Given this list of marker genes Tnfsf4, Cd74, Sh3kbp1, Ctla4, Supt6, Nckap1l, Tgfb1, Cd19, Cd22, Bmi1, Tnfsf13b, Lyn, Pcid2, Pkn1, Cd320, Pten, Inpp5d, Exosc3, Mir181b-2, Tbx21, Aplf, Flt3, Shld1, Lilrb4a, Il2rg, Xbp1, Peli1, Il4, Stat5a, Ndfip1, Mef2c, Bcl2, Ankle1, Tlr9, Ptprc, Themis2, Tbc1d10c, Ifng (interferon gamma), Bank1, Il27ra, Zfp36l1, Bst1, Mlh1, Foxj1, Cyld, Parp3, Tlr4, Shld3, Stat5b, Tnfrsf13b, Il5, Nfatc2, Ptpn6, Kmt5c, Rc3h1, Btk, Il13 (interleukin 13), Mif, Mir150, Ighm, Cd40lg, Nfam1, Wnt3a, Trp53bp1, Tsc2, Ppp2r3c, Clcf1, Btla, Hmces, Ahr, Id2, Ighd, Sash3, Slamf8, Il21, Tnip2, Slc39a10, Tnfsf13, Sfrp1, Pagr1a, Cd28, Exosc6, Bad, Shld2, Il3, Il2, Mmp14, Tnfaip3, Laptm5, Fas, Msh2, Zfp36l2, Samsn1 (SAM domain, SH3 domain and nuclear localization signals, 1), BC037156, Pnp, Irs2, Ticam1, Slc15a4, Cd24a, Vav3, Chrnb2, Kmt5b, Siglecg, Cd27, Gpr183, Il6, Mad2l2, Mzb1, Cd81, Paxip1, Ada, Mir181b-1, Tyrobp, Stat6, Cd300a, Il7, Tnfrsf4, Ddrgk1, Tnfrsf13c, Prlr, Card11, Ephb2, Il10, Nsd2, Cdkn1a, Nod2 (nucleotide-binding oligomerization domain containing 2), Rif1, Pawr, Syk, Cdkn2a, Atad5, Akirin2, Tcf3, Atp11c, Ikzf3, Hmgb3, Pms2, Fcgr2b, Tnfrsf21, Cd38, Atm, Foxp3, Tirap, Cd40, Tfrc, Il4i1, Spi1, Bcl6, Casp3 (NCBI Gene Id 12367), here is a description of the gene set: Any process that modulates the frequency, rate or extent of B cell activation. Mouse Gene Set: GOBP_REGULATION_OF_B_CELL_ACTIVATION studied in species Mus musculus